Given this list of marker genes WNT5A, MSX2, DAZL (deleted in azoospermia like), PRDM9, RPS6KA2, NANOS2 (nanos C2HC-type zinc finger 2), CDC20, MSX1, WNT4, OOEP, CALR, PSMA8, PDE3A, LIF, STRA8, FBXO5, DMRT1, ZWINT, FBXO43, RAD51AP1, UBE2B, NPM2, TRIP13, WEE2, KNL1 (NCBI Gene Id 57082), HORMAD1, PIWIL2, PLCB1, GPR3, FZR1, MOS, SIRT2, RAD1, MEIOSIN, NPR2, here is a description of the gene set: Human Gene Set: GOBP_REGULATION_OF_MEIOTIC_NUCLEAR_DIVISION species: Homo sapiens Any process that modulates the frequency, rate or extent of meiotic nuclear division, the process in which the nucleus of a diploid cell divides twice forming four haploid cells, one or more of which usually function as gametes.